Given this list of marker genes MAPK8, MAPK10, FOS, MAP2K4, MAPK9, MAP3K5, MAP2K7, JUN, here is a description of the gene set: species: Homo sapiens Pathway Definition from KEGG: Metals -> ROS -> MAP3K5 -> MKK4/7 -> JNK -> AP1 Human Gene Set: KEGG_MEDICUS_ENV_FACTOR_METALS_TO_JNK_SIGNALING_PATHWAY Metals to JNK signaling pathway. Pathway ID: N01407. Pathway type: Env factor. Pathway class: nt06211 Other MAPK signaling.